The following is a description of a gene set: The presence of a dilated urinary bladder. Dilatation of the bladder Human Gene Set: HP_DILATATION_OF_THE_BLADDER species: Homo sapiens, and this is the list of marker genes: AVPR2, NKX2-1, FOXF1, MYOCD, TP63, LRIG2 (NCBI Gene Id 9860), MYLK, LMOD1, MYH11, ACTG2, AQP2, MYL9